The following is a description of a gene set: Genes down-regulated in CD40L and IL-2 IL-4 IL-5 stimulated at day 1 B cell IRF4intermediate versus CD40L and IL-2 IL-4 IL-5 stimulated at day 1 B cell wildtype. Temporal analysis of B cell activation in vitro using CD40L and IL-2/4/5 cytokines in wild type Irf4+/+ B cells or in mutant Irf4-/- B cells harboring a tet-inducible allele of Irf4. IRF4 expression was restored, or not, in the Irf4-/- background by culturing in the presence of low or high concentrations of doxycycline. The results provide insight in the role of IRF4 expression levels in coordinating different programs of B cell differentiation. studied in species Homo sapiens Human Gene Set: GSE46606_IRF4MID_VS_WT_CD40L_IL2_IL5_DAY1_STIMULATED_BCELL_DN from publication Ochiai K, Maienschein-Cline M, Simonetti G, Chen J, Rosenthal R, Brink R, Chong AS, Klein U, Dinner AR, Singh H, Sciammas R (PMID 23684984), and this is the list of marker genes: CCDC88B, IRAK3, TFF1 (trefoil factor 1), RBBP8, EPDR1, STARD5, SLC39A14, HCAR2, AGXT, B3GAT1, HTR3A, TNIP1, FNBP1L, PHF8, F3, CCL4, FOXP4, TRIM13, BMAL2, KRT222, EFS, NMUR2, ETS2, GFI1, SEMA4D (NCBI Gene Id 349236), PIK3R5, AK4, ZNF572, LYPD4, SNX10, DUSP1, ICAM1, GALR2, ESRRA, MARCKSL1, HMGB2, PTPN1, NFKBIB (NCBI Gene Id 4793), TOGARAM2, HOOK3, RICTOR, ZFAND5, RAB11FIP1, MEX3C, DUSP16, REST, SPAG5, RHBDF2, SPRED1, SNX18, HAPLN2, KPNA3, LSM11 (LSM11, U7 small nuclear RNA associated), GSPT1, ICOSLG, SUSD6, TRIP13, NLRP3, ACCSL, AQP4, RASGEF1B, ARHGAP31, GALNT16, ST3GAL1, NFKBIA, ZDHHC22, ANKRD33B, SKA1, NFKBIE, BIRC3, TNF, SHROOM3, MIR22HG, RAB20, CCDC71L, PLEK, SGMS1, ABRACL (NCBI Gene Id 58527), SALL2, PIK3CG, NXPE3, TRAPPC6B, ZNF800, CRY1, TLR2, CORT, REPS1, TTC23L, LELP1 (late cornified envelope like proline rich 1), IFT57, PLEKHM3, PRDM2, SPIC, CDIPTOSP, NFKB1, RALGDS, SH2D2A, CUZD1, SH3BP4, SMG8, WTAP, PDE4B, TNFAIP3, PTPN12, PTPN23, RNF19B, NCK1, WNT6, ZDHHC5, ABHD17C, GCOM1, SLC30A6, NFKB2, CD69, ANO9, WSB1, SAMSN1, TTYH1, TANK, LENG9, RASGRP1, BATF, GABRA5, EPPIN (epididymal peptidase inhibitor), OPRK1, MAFF, DTX1, KRT2, CCDC198, TMEM170B, SIRPA, EHD1, CFLAR, OSGIN2, MAPKAPK2, HIVEP1, CSNK1A1, ADORA2B, OLR1, NR6A1, ATF7IP2, INSIG1, GUCA2B, FZD1 (NCBI Gene Id 8321), CSF3, DGKI, MALT1, LRRC8C, ZC3H12C, KRT71, NFKBIZ, KCNQ4, GLRB, VASP, LCP2, NODAL, FOXN2, CDYL, SOCS3, KLF7, SLC16A10, PROB1, APBB1IP, ZSWIM4, GCH1, RAB32, PLPPR4, TLNRD1, GPD2, MITF, N4BP1, TNFAIP2, RNF19A, HTR7, VTA1, PFDN4, CPEB4, CTNNA3, IRAK2, ZNF799, ARHGAP42, LZTFL1, KIT, ABTB2, EEIG2, CEBPD, REL, CLIP2, SYK, ITGB8, TPTE, KIF3C, HMGCS2, HSD17B7, NDEL1, FAM227A, CALCRL, TNFSF9, CH25H